Given this list of marker genes Exosc1, Serp1, Exosc9, Atp6v0d1, Dcp1a, Pdia6, Imp3, Lsm4, Igfbp1 (insulin-like growth factor binding protein 1), Fus, Srpra, Dctn1, Eif4e, Edc4, Khsrp, Dnajc3, Pdia5, Dkc1, Skic3, Dcp2, Cebpg, Xbp1, Nolc1, Tubb2a, Spcs1, Gemin4, Arxes2, Eif4g1, H2ax, Eif2s1, Eif4a3, Eef2, Gosr2, Hsp90b1, Mthfd2, Asns, Nfyb, Nhp2, Iars1, Exosc5, Sec11a, Edem1, Eif4a2, Banf1, Yif1a, Tatdn2, Preb, Stc2, Tars1, Wipi1, Cebpb, Hspa5, Cnot4 (CCR4-NOT transcription complex, subunit 4), Vegfa, Fkbp14, Hspa9, Exosc2 (exosome component 2), Ero1a, Nabp1 (nucleic acid binding protein 1), Exoc2, Shc1, Calr, Cnot2, Atf3, Eif4ebp1, Herpud1, Rps14, Bag3, Slc30a5, Kif5b, Slc7a5, Paip1, Zbtb17 (NCBI Gene Id 22642), Eif4a1, Dnajb9, Parn, Ern1, Eif2ak3, Nop56, Ssr1 (signal sequence receptor, alpha), Exosc4, Npm1, Hyou1, Pop4, Lsm1, Atf4, Nfya, Wfs1, Rrp9, Xpot, Kdelr3, Nop14, Atf6, Dnaja4, Arfgap1, Srprb, Chac1, Ywhaz, Aldh18a1, Sec31a, Ddx10, Sdad1, Exosc10, Cnot6, Cxxc1, Cks1b, Mtrex, Slc1a4, Psat1, Tspyl2, Ddit4, here is a description of the gene set: Mouse genes annotated to HALLMARK_UNFOLDED_PROTEIN_RESPONSE based on orthology mappings provided by the Alliance Genome Consortium from publication Howe DG, Blake JA, Bradford YM, Bult CJ, Calvi BR, Engel SR, Kadin JA, Kaufman TC, Kishore R, Laulederkind SJF, Lewis SE, Moxon SAT, Richardson JE, Smith C (PMID 30224793) studied in species Mus musculus Mouse Gene Set: HALLMARK_UNFOLDED_PROTEIN_RESPONSE